The following is a description of a gene set: Human Gene Set: HEBERT_MATRISOME_TNBC_BRAIN_METASTASIS We have previously developed methods for enriching tissue samples for their ECM protein content by taking advantage of the relative insolubility of the ECM, and we have used these techniques in conjunction with mass spectrometry-based proteomics to profile the matrisome, the complete collection of both core ECM and ECM-associated proteins, in several different cancers. Here we define and compare the ECM components of metastatic niches and how they differ among the specific secondary sites common in TNBC. For this purpose, we use as a model the MDA-MB-231 human TNBC cell line, originally derived from a patient pleural effusion (24), which is capable of metastasizing to the brain, lungs, liver and bone marrow in mouse xenografts. We identify which ECM proteins are commonly elevated at multiple different metastatic sites, and which are preferentially elevated in particular sites. We investigate how these specific ECM proteins, as well as the tumor matrix overall, are differentially produced by the tumor and stromal cells; in this paper, we use stromal to include all cells in the tumor that are not tumor cells. These comparisons did not simply identify the most elevated proteins in each tissue, but rather the proteins most significantly different in abundance in one tissue relative to all others. Separate analyses were conducted for tumor-cell-derived (human) and stroma-derived (mouse) proteins. In this study, we performed an unbiased, quantitative mass spectrometric survey of ECM proteins present in MDA-MB-231 breast cancer xenograft metastases to the brain, lungs, liver and bone marrow. This gene set lists the matrisome proteins found in significantly higher abundance in TNBC brain metastasis niche compared to TNBC bone, liver and lung metastatic niches. Matrisome proteins found in significantly higher abundance in TNBC brain metastasis niche compared to TNBC bone, liver and lung metastatic niches. from publication Hebert JD, Myers SA, Naba A, Abbruzzese G, Lamar JM, Carr SA, Hynes RO (PMID 32019869) species: Homo sapiens, and this is the list of marker genes: AGRN (agrin), SERPINB1, ACAN, COL23A1, CD109, VWA1, FREM1 (FRAS1 related extracellular matrix 1), CBLN1 (NCBI Gene Id 869), HMCN1, CSPG4, INTS14, LGALS3, SERPINE2, THBS4, EGFL7, HPX, LGI1, TNR, BCAN, LAMA1, HCFC1, COL4A5, C1QC, SERPINH1, FGF14, ADAM22